Given this list of marker genes Ppp1r1b, Fuom (fucose mutarotase), Ncoa2, Drd5, Ncoa1, Pgr, Vmn2r116, Thrb, Avp, Esp1, Avpr1a, Thra, Trpc2, Oxt, here is a description of the gene set: The specific behavior of a female organism that is associated with reproduction. species: Mus musculus Mouse Gene Set: GOBP_FEMALE_MATING_BEHAVIOR